Given this list of marker genes Tbx5, Shh, Nfatc3, Pitx2, Tbx10, Vegfa, Gata6, Nfatc2, Fgf8, Isl1, Bmp4, Ptpn11, Srf, Foxh1, Mapk1, Vegfb (NCBI Gene Id 22340), Notch1, Smad4, Hand2, Hey2, Smad1, Bhlhe40, Ctnnb1, Fgf10, Tbx2, Nfatc4, Vegfc, Bmp2, Erbb3, Gata4, Bmpr1a, Hey1, Nfatc1, Mir145a, Irx4, Bmp10, Foxc1, Foxa2, Mef2c, Hand1, Smyd1, Nkx2-5, Tbx20, Mir143, Foxc2, Bmpr2, here is a description of the gene set: species: Mus musculus Mouse Gene Set: WP_HEART_DEVELOPMENT Heart development